Given this list of marker genes TNF, TRADD, TNFRSF1A, RIPK1, TRAF2 (NCBI Gene Id 7186), TRAF5, RIPK3, here is a description of the gene set: TNF-RIPK1/3 signaling pathway. Pathway ID: N01621. Pathway type: Reference. Pathway class: nt06527 Necroptosis. species: Homo sapiens Pathway Definition from KEGG: TNF -> TNFRSF1A -> (TRAF2/5+TRADD+RIPK1+RIPK3) Human Gene Set: KEGG_MEDICUS_REFERENCE_TNF_RIPK1_3_SIGNALING_PATHWAY